The following is a description of a gene set: Genes having at least one occurrence of the motif NCTGATTGGYTASY in the regions spanning 4 kb centered on their transcription starting sites. This matches the transcription factor binding site V$NFY_C (v7.4 TRANSFAC). Human Gene Set: NFY_C studied in species Homo sapiens, and this is the list of marker genes: HNRNPL, CCDC89, RACGAP1, MRPS30, STMN4, DDR2, MLEC, MYOCD, IL1RAPL1, OGG1, CELSR3, ZNF14, MRPL51, KIF23, NCEH1, GNGT2, FAM117A, SEL1L, ABI3, IFT27, PEX2, BLK, SUZ12, HSCB, USP21, TPP2, TESK2, DNAJB11, FXR2, TYSND1, H3-3B, MTX1, GTF2I, H4C3, KCNJ13, HNRNPA0, PBX1, GSK3B, MCM8 (minichromosome maintenance 8 homologous recombination repair factor), RAG1, RBM4, ATOH1, SYCP3, AP3M2, THBS3, GCA, ADAMTS19, EHF, COL1A1, RBM10, ZNF385A, CEP57, FUT8, ADAMTSL1, SFRP1, SLC12A1, AMTN, C1QTNF6, LDB2, WNT3, NFATC4, PIK3R1, TMA7, BCAS3, SPAG7, NFYA, BRD8, OARD1, KLHL4, BAZ1A, TAF15, GTF2A1L (general transcription factor IIA subunit 1 like), M6PR, WBP2, FDFT1 (farnesyl-diphosphate farnesyltransferase 1), FOXN3, CLDN8, TRADD, EIF2AK3, ESPL1, YARS1, HCP5, H3C1, CDH9, MRPL50, ELMO1, KAT7, LHX1, SOX2, ZNF362, NEUROG3, ACVR1, STARD7, FDPS, KATNB1, PPP2R5C, SNRPA (small nuclear ribonucleoprotein polypeptide A), MAZ, POU3F3, SIAH3, PPM1B, H2AC1, CCDC51, CAT, PAX6, MROH8, SLC9C2, HOXC4, ETV5, LIN28A, IFFO1 (NCBI Gene Id 25900), SKIDA1, GUCA2A, ENSA, NCAPD2, LYRM7, H2BC1, H2BC4, NFYC, DCAF11, ESRRG, ACYP1, MTFP1, HIGD1A, LRP8, PIGA, MRTFA, RPS6KA5, WNT8B (Wnt family member 8B), MCTS1, FAM76B, FBXL8, CDC25A, SIX5, DUSP10, KIF20A, CALM2, DLG3, NUP98, ELAC2 (elaC ribonuclease Z 2), CNNM2, BAHD1 (bromo adjacent homology domain containing 1), SIK3, MIR22HG, GNAI2, PXMP4, UHRF1, LMOD1, HLA-DOA, HDAC1, MED30, TMEM108, HOXD10, MAP3K3, HLA-DQB2, SORBS2 (NCBI Gene Id 8470), SPOCK2, MYO1E (myosin IE), DLEU2, HELB, TCERG1, HLA-F, ZNF436, SSBP3, SPC25, RPA2, EXD1, RPRD2, PRDM13, FGF4, ARL6IP6, MAEL, ZNF775, TLE4, ZNF597, DMD, ACTL6A, TRAF3IP2, KLF1, ACR (NCBI Gene Id 49), SEPTIN4, ADCY10, COA3, ARRDC3, SESN2, TAF8, RPN2, IER5L, SATB2, ANO4, GPC3, PLN, ARL17A, CDK2AP2, TENM3-AS1, ACTMAP, ABCA7, NDUFS8, TMEM184C, PTF1A, RREB1, SHH, UBXN11, CHP1, UBE2C, AMELY, CKS2 (NCBI Gene Id 1164), DLEU1, LIX1, WASF2, CDH6, TFCP2, ZBTB5, COL5A3 (collagen type V alpha 3 chain), SMAD2, CNTD1, HNRNPA1, H4C1, TECR, ZNF189, HAND2, MIS12 (MIS12 kinetochore complex component), PCYT1B, NOL4, NCAM1, CHAC1, TSPAN13, VPS50, DDIT3, HOXC8, EZHIP (NCBI Gene Id 340602), TRMT6, ZBTB10, ZFP91, ZDHHC5, H2AC6, CBX5, AGFG2 (NCBI Gene Id 3268), ARL6IP1, PI4K2A, SP140L, RBM14, MBNL1, PRPF38B, CBLB, WDR81 (NCBI Gene Id 780925), SPTB, DGKZ, ELAVL4, ERG28